The following is a description of a gene set: Genes consistently overexpressed with age, based on meta-analysis of microarray data. studied in species Homo sapiens from publication de Magalhães JP, Curado J, Church GM (PMID 19189975) Human Gene Set: DEMAGALHAES_AGING_UP MOTIVATION: Numerous microarray studies of aging have been conducted, yet given the noisy nature of gene expression changes with age, elucidating the transcriptional features of aging and how these relate to physiological, biochemical and pathological changes remains a critical problem. RESULTS: We performed a meta-analysis of age-related gene expression profiles using 27 datasets from mice, rats and humans. Our results reveal several common signatures of aging, including genes consistently overexpressed with age, the most significant of which was APOD, and genes underexpressed with age. We characterized the biological processes associated with these signatures and found that age-related gene expression changes most notably involve an overexpression of inflammation and immune response genes and of genes associated with the lysosome. An underexpression of collagen genes and of genes associated with energy metabolism, particularly mitochondrial genes, as well as alterations in the expression of genes related to apoptosis, cell cycle and cellular senescence biomarkers, were also observed. By employing a new method that emphasizes sensitivity, our work further reveals previously unknown transcriptional changes with age in many genes, processes and functions. We suggest these molecular signatures reflect a combination of degenerative processes but also transcriptional responses to the process of aging. Overall, our results help to understand how transcriptional changes relate to the process of aging and could serve as targets for future studies. AVAILABILITY: http://genomics.senescence.info/uarrays/signatures.html. SUPPLEMENTARY INFORMATION: Supplementary data are available at Bioinformatics online., and this is the list of marker genes: GFAP, EFEMP1, VAT1, IL33, FCGR2A, LGALS3, NPC2, CTSS, MPEG1, PTGES3, LITAF, MGST1, HBA1, ADIPOR2, ANXA3, MSN, APOD, ANXA5, PSMD11, FCGR2B, PCSK6, GPNMB, TXNIP, S100A6, C3, MT1F, SPP1, GSTA1, SERPING1, H1-2, C1QB, LAPTM5, LYZ, NDRG1 (N-myc downstream regulated 1), CLU, GBP2, CLIC4, TMED10, DCLK1, RASA3, JCHAIN, RNF213, VWF, HLA-G, B2M, C4A, GNS, EFCAB14, C1QC, DERL1, SGK1, HCST, S100A4 (S100 calcium binding protein A4), C1QA